The following is a description of a gene set: Human Gene Set: GOBP_GALACTOSE_CATABOLIC_PROCESS_VIA_UDP_GALACTOSE_LELOIR_PATHWAY The chemical reactions and pathways resulting in the breakdown of galactose, via the intermediate UDP-galactose. studied in species Homo sapiens, and this is the list of marker genes: GALT, PGM1, GALK1, GALE, GALM